Given this list of marker genes Cltb, Pfdn5, Gadd45g, Ubb, Swi5, Atf4, Fth1, Gpx3, Map1lc3a, Tmem176a, Ptma, Use1, Ier3, Sertad1, Gstm1, Ms4a4d, Cxcl1, Ifi27, Rpl14, Smim3, Gpx4, Dad1, Slc25a3, Ftl1, Eef1d, Plac9, Skil, Junb, Apoe, Cd63, Ccl7, Ankrd1, Tnfaip6, Isg20, Anxa3, Mt1, Zfp36l1, H2-K1, Crlf1, Ccl19, Rpl31-ps12, Nfkbib, H2-D1, Capg, Tspo, Cebpd, Ccl2, Ctsl, Tuba4a, Cfl1, Gadd45b, Cyb5a, S100a6, Fosl2, Tmem176b, Cdk2ap2, Cdkn1a, Cst3, Jund, Mt2, Ccnl1, Rpl13, Rnase4, Rhoh, Eif5a, Srgn, Ndrg1, Malat1, Ifitm2, Hint1, Chmp2a (charged multivesicular body protein 2A), Calm1, Dcn, Plekhf1, Zfp36, Gadd45a, Ccl11, Arpc3, Gja1, Bsg, Sbsn, Hspb1, Gabarap, Casp4, Eif1, Rhoc, Eif3k, Rpl6, Klf2, Anxa1, Pnp, Tpm3, Kdm6b, Rabac1, Ubb-ps, Gstm2, Slc10a6, Emd, Map1b, Id3, Rpl13a, Pold4, Nfkbia, H2-Q4, Gstp1, Nop58, Fos, Ifitm3, Crip2, Serpinf1 (serine (or cysteine) peptidase inhibitor, clade F, member 1), B2m, Nop53, Tagln2, Rarres2, Pttg1, Rps27, here is a description of the gene set: from publication Tabula Muris Consortium (PMID 32669714) Mouse Gene Set: TABULA_MURIS_SENIS_LIMB_MUSCLE_SKELETAL_MUSCLE_SATELLITE_CELL_AGEING studied in species Mus musculus